Given this list of marker genes NEFH, RPA2, WEE1, RNF32, RFC4, HLTF, SLFN13, RMI2, TCAM1P, TMEM41A, CDKN2A, PRPF38A, SDHAP4, ZFR2, LINC01305, WNK3, TOPBP1, LIG1, EIF2B5, SOWAHA, PDCD10, MLH1, RNF168, USP1, CXCL17, NEXMIF, HS6ST2, ACTL6A, NR1D2, GK5, EHHADH, POLR2H, FAM111B (NCBI Gene Id 374393), MEIS1, NDUFB5, MSL2, SLF1, RIBC2, MCM6, CDKN2C, TAF7L, NEPRO, CDC7, C9orf40, DHFR, SYNGR3, TFDP2 (NCBI Gene Id 7029), KIF15, HES1, ASS1, EZH2, SPICE1, CRYGS, DNAJC13, CENPW, NMU, HAUS5, CENPK, YBX2 (NCBI Gene Id 51087), FMR1, RAP2B, INPP5B, NUP210, ABCA17P, RAD18, WDR53, ALG6, C5orf34, MCM2, NR2C2AP, SYCE2, SENP5, MYNN, MAJIN, CELSR3, RMI1, MEI1, KCNS1, ZPBP2, here is a description of the gene set: from publication Slebos RJ, Yi Y, Ely K, Carter J, Evjen A, Zhang X, Shyr Y, Murphy BM, Cmelak AJ, Burkey BB, Netterville JL, Levy S, Yarbrough WG, Chung CH (PMID 16467079) Genes up-regulated in head and neck squamous cell carcinoma (HNSCC) samples positive for HPV compared to the HPV-negative tumors. Human papillomavirus (HPV) is associated with a subset of head and neck squamous cell carcinoma (HNSCC). Between 15% and 35% of HNSCCs harbor HPV DNA. Demographic and exposure differences between HPV-positive (HPV+) and negative (HPV-) HNSCCs suggest that HPV+ tumors may constitute a subclass with different biology, whereas clinical differences have also been observed. Gene expression profiles of HPV+ and HPV- tumors were compared with further exploration of the biological effect of HPV in HNSCC. Thirty-six HNSCC tumors were analyzed using Affymetrix Human 133U Plus 2.0 GeneChip and for HPV by PCR and real-time PCR. Eight of 36 (22%) tumors were positive for HPV subtype 16. Statistical analysis using Significance Analysis of Microarrays based on HPV status as a supervising variable resulted in a list of genes that were differentially expressed with statistical significance. Results for a subset of these genes were verified by real-time PCR. Genes highly expressed in HPV+ samples included cell cycle regulators (p16(INK4A), p18, and CDC7) and transcription factors (TAF7L, RFC4, RPA2, and TFDP2). The microarray data were also investigated by mapping genes by chromosomal location (DIGMAP). A large number of genes on chromosome 3q24-qter had high levels of expression in HPV+ tumors. Further investigation of differentially expressed genes may reveal the unique pathways in HPV+ tumors that may explain the different natural history and biological properties of these tumors. These properties may be exploited as a target of novel therapeutic agents in HNSCC treatment. studied in species Homo sapiens Human Gene Set: SLEBOS_HEAD_AND_NECK_CANCER_WITH_HPV_UP